Given this list of marker genes Orai1, Lgals3, Lhcgr, Cxcl11, Pln, Nfatc3, Capn3, Kcnn4, Casr, Itpr1, Spink1, Ahnak, Rcvrn, Bdkrb1 (bradykinin receptor, beta 1), Vdac1, Fyn, Rhoa, Ffar1, Grm6, Epb41, Atp2c2, Ace, Drd2, Tlr9, Fbxo11, Cxcl10, Cacna1b, Epo, Atp2b2, Fkbp1b, Grin1, Cacng6, Dysf, Cd19 (NCBI Gene Id 12478), Hpca, Gpr39, Atp2a1, Dspp, Stimate, Drd1, Jak3, Trpc4, Snca, Ccl5, Rem1, Trpv3, Sumo1, Hes1, Akap6, Ppp3ca, Cckar, Icam1, Rgs9, Gnai2, Ccr1, Ucp2, Trim27, Pdgfrb (NCBI Gene Id 18596), Stim1, Cacnb4, Cyba, Nppa, Stc1, Cacna1g, Gja1, Cacnb2, Dhrs7c, Atp1b1, Ubqln1, Pkd2, Cacnb1, Fkbp1a, Strit1, Tgfb1, Crh (NCBI Gene Id 383938), Pdpk1 (NCBI Gene Id 18607), Ank2, Nol3, P2rx1, G6pdx, Cd84, Gper1, Cacnb3, Jph2, Itgb3, F2rl3, Slc9a1, Tspan18, Inpp5k, Nipsnap2, Trpc1, Vmp1, Eppin, Slc8a1, Stac3, Ehd3, Npsr1, Saraf, Ucn, Il16, Nos1, P2ry12, Ccr1l1, Isl1 (ISL1 transcription factor, LIM/homeodomain), Lime1 (NCBI Gene Id 72699), Gcg, Stim2, Homer2, Abl1, Igf1, Tmbim6, Cxcl12, Cbarp, Atg5, Ngf, Sln, Mylk, Pacsin3, Hspa2, Akap5, Glp1r, Spg11, 1810037I17Rik, Trpc3, Ywhae, Gimap5, Ctnnb1, Hap1 (NCBI Gene Id 268486), Pdgfb, Tmem38a, Prkce, Asph, Ppp3cc, Fmr1, Tspan13, Gpr35 (NCBI Gene Id 64095), Mcub, Cxcl9, Gjc2, F2, Homer1, Bak1, Gimap3, Afg3l2, Bin1, Drd4, Rgs4, Wfdc6a, Ccl3 (NCBI Gene Id 20302), Trdn, Ryr2, Coro1a, Gnao1, Tspo, Cx3cl1, Ubash3b, Calm1, P2rx4, Tmc2, Clec4b1, Cracr2a, Tmx1, Grin3b, Smim6, Bmp4, Gsto1, Sestd1, Agtr1a, Selenon, Ptgs2, Tgfb2 (transforming growth factor, beta 2), Ptk2b, Gstm7, Plp1, Prnp, Vdr, Wnk3, Slc30a1, Prkd1, Homer3, Nos3, Ntsr1, Pawr, Stc2, Ccl12, F2r, P2rx5, Lpar3, Chd7, Atp2b1, Oga, Cav3, Atp1a2, Aplnr, Calm2, Diaph1, P2ry6, Spg7, Cldn16, Calm3, Sri, Gramd2a, Jsrp1, Trpc6, Bax, Cacna2d1, Adora2a, Aqp2, Psen2 (NCBI Gene Id 98295), Akt1, Ppp3cb, Ms4a1, Lilra5, Ahr, Jph3, Ptpn22, Usp2, Selenok, Lyn, Crhr2, Cacna1c, Plcg2, Plcg1, Rapgef3, Casq1, Camk2a, Egf, Cacng1, Efhb, Bcl2, Tmc1, Stac, Htt, Slc8b1, Cacna1f, Adrb2, Ms4a2, Cask, Camk2d, Plpp4 (NCBI Gene Id 403184), Ppp3r1, Il13, Mrln, Jph4, Myo5a, Ubr3, Thy1, Agt, Tmem38b, Ptger3, Trpv2, P2rx7, Xcl1, Mchr1, Dmd, G6pd2, Ednra, Fgf14, Mettl21c, Cav1, Oprd1, Hcrt, Fcrl5, Cxcr3, Zfas1, Pde4d, Ptpn6, Cemip, Pik3cg, Creb3, Cd4, Pml, Gnb5, Hrc, Dbi, Serpine1, Ppp3r2, Cxcr4, Wfs1, Cacna1d, Catsper1, Best1, Stac2, Adrb1, Arrb2, Adcyap1r1, Casq2, here is a description of the gene set: Any process that modulates the frequency, rate or extent of the directed movement of calcium ions into, out of or within a cell, or between cells, by means of some agent such as a transporter or pore. Mouse Gene Set: GOBP_REGULATION_OF_CALCIUM_ION_TRANSPORT studied in species Mus musculus